The following is a description of a gene set: Very rapid breathing. Tachypnea studied in species Homo sapiens Human Gene Set: HP_TACHYPNEA, and this is the list of marker genes: KATNIP, TOPORS, BOLA3, PDE6D, CACNA1S, HMGCL, SLC34A2, INPP5E, IFT74, ARL13B, PLXND1, CC2D2A, CEP41, TCTN2, FAM149B1, NEK1, PAM16, FBP1, ZNF423, CEP120, AHI1, PCCA, CSF2RB, PIBF1, ARSL, SUFU, ASL, NAGS, CASR, LRPPRC, CPLANE1, PCCB, KIAA0586, MECP2, TOGARAM1, RHD, COPA, MKS1, ACTA2, OFD1, TMEM218, CSPP1, TMEM231, TMEM237, CEP104, RHAG, CDKL5, SMC1A, NKX2-6, LYRM7, OXCT1, TCTN1, KIAA0753, GET3, CEP290, NHLRC2, RHCE, B9D2, TMEM216, NKX2-1, B9D1, COA6, CSF2RA, TMEM67, CA5A, IGHMBP2, SFTPB, MT-CYB, HLCS, STING1, TCTN3, SLC25A15, ABCD4 (ATP binding cassette subfamily D member 4), FARSB, UQCRC2, ARMC9, ATP5F1B, RPGRIP1L, HYLS1, BTD, NTNG1, ARL3, RYR1, CBY1, ACAT1, GABBR2, KIF7, SFTPC, TMEM138, ABCA3, TLL1, SCO2, TBX1, ACADVL